Given this list of marker genes HPN, SMARCB1, SMARCA4, CCNT2, ZNF639, CCNT1, TFAP4, CTDP1, NUCKS1, EP300 (NCBI Gene Id 2033), RRP1B (NCBI Gene Id 23076), SP1, CDK9, LEF1, SNW1, CHD1, JUN, TAF11, here is a description of the gene set: Any process in which a host organism activates or increases the frequency, rate or extent of viral transcription, the synthesis of either RNA on a template of DNA or DNA on a template of RNA. studied in species Homo sapiens Human Gene Set: GOBP_POSITIVE_REGULATION_BY_HOST_OF_VIRAL_TRANSCRIPTION